The following is a description of a gene set: FCERI mediated NF-kB activation studied in species Mus musculus Mouse Gene Set: REACTOME_FCERI_MEDIATED_NF_KB_ACTIVATION, and this is the list of marker genes: Bcl10, Psmc1, Ighv8-5, Ighv12-3, Igkv2-109, Psmc3, Igkv1-88, Psma4, Igkv2-112, Igkv1-135, Traf6, Igkv1-132, Igkv1-133, Ubb, Psmc4, Igkv1-110, Ighv6-3, Psmb6, Igkv17-121, Igkv15-103, Ube2d1, Ighv3-8, Psmb1, Fcer1g, Igkv8-21, Ighv8-11, Iglc2, Uba52, Ube2d2a, Igkv2-137, Ube2v1, Psmd1, Malt1, Ighe, Ighv5-9, Map3k7, Igkv11-125 (NCBI Gene Id 243428), Igkv1-117, Ighv6-6, Psmb2, Psmc6, Ubc, Adrm1, Rps27a, Psma6, Ighv8-6, Psmd11, Psma3, Skp1, Iglc1, Psma1, Psma7, Pdpk1, Ighv8-13, Nfkb1, Cdc34, Ighv5-16, Igkv1-131, Igll1, Chuk, Ms4a2, Ighv13-2, Ighv8-9, Cul1, Psmb7, Ikbkg, Prkcq, Ube2n, Ighv5-2, Fcer1a (Fc receptor, IgE, high affinity I, alpha polypeptide), Psmd7, Ighv5-12, Fbxw11, Psmb4, Psmd8, Psmd12 (NCBI Gene Id 66997), Ighv5-6, Psmc2, Ighv16-1, Ighv3-6, Nfkbia, Psmd2, Psmd14, Uba52rt (NCBI Gene Id 676687), Card11, Tab2, Ighv5-12-4, Ighv3-3, Igkv1-35, Ighv6-7, Rela, Igkv20-101-2, Psmd13, Ikbkb, Ighv6-5, Psmd6, Tab1, Ighv7-3, Ighv5-9-1, Igkv18-36, Ighv5-17, Ighv8-2, Ighv8-12, Psma2, Psmb3, Ighv5-15 (immunoglobulin heavy variable 5-15), Igkv1-99, Ighv6-4, Igkv16-104, Ighv7-4, Ighv3-5, Igkv1-122, Psmb5, Psma5, Ighv7-2, Ighv8-4, Ighv5-4, Psmc5, Ighv3-1, Ighv3-4, Ighv8-8, Lyn, Psmd3, Tab3